Given this list of marker genes ZSWIM1, CSRNP3, TUB, TRERF1, IFT57, PTMS, INO80B (NCBI Gene Id 83444), CCDC13, DCTN3, NUDC, ARFIP1, OSBPL2, LRP10, OSR2, GTF3C1, TEX2, DIS3, MORN4, MBNL2, OSM, C2orf15, P2RY10, NR4A3, DNAAF6 (NCBI Gene Id 139212), NUP62CL, SLCO3A1, HNRNPF, PURG, FRA10AC1, WRN, PIM2, CAMK1, STRN4, RGS6, EFHB, SMARCAD1, FKRP, NR4A1, PIH1D2, CEP135, KCNK12, GLRX5, MID2, PPP1R16A, IL34, RREB1, NOS1, FNDC9, ITGB3BP, DNAJC21, GAST, TBC1D16 (NCBI Gene Id 54493), SREK1, HPCAL1, MAPRE3, FBXL2, PCF11, PIBF1, TSGA10, OTX1, CYRIA, PRRT2, RFX1, CAMK2A, NKAPD1, KIFAP3, WDR47, STAT6, CCDC24, SYT17, DNAJA1, FGF9, SLC9A7, KDM3A, TIGD4, TMEM209, RARA, SLC8A3 (NCBI Gene Id 90450), LINC01567, TMEM254, TSHZ2, MINK1, CHD4, RAB28, UNG, RAB36, GOLM2, MGAT4B, NIM1K, NLGN2, here is a description of the gene set: Human Gene Set: GTTNYYNNGGTNA_UNKNOWN Genes having at least one occurrence of the highly conserved motif M89 GTTNYYNNGGTNA in the regions spanning 4 kb centered on their transcription starting sites. The motif does not match any known transcription factor binding site. Comprehensive identification of all functional elements encoded in the human genome is a fundamental need in biomedical research. Here, we present a comparative analysis of the human, mouse, rat and dog genomes to create a systematic catalogue of common regulatory motifs in promoters and 3' untranslated regions (3' UTRs). The promoter analysis yields 174 candidate motifs, including most previously known transcription-factor binding sites and 105 new motifs. The 3'-UTR analysis yields 106 motifs likely to be involved in post-transcriptional regulation. Nearly one-half are associated with microRNAs (miRNAs), leading to the discovery of many new miRNA genes and their likely target genes. Our results suggest that previous estimates of the number of human miRNA genes were low, and that miRNAs regulate at least 20% of human genes. The overall results provide a systematic view of gene regulation in the human, which will be refined as additional mammalian genomes become available. species: Homo sapiens from publication Xie X, Lu J, Kulbokas EJ, Golub TR, Mootha V, Lindblad-Toh K, Lander ES, Kellis M (PMID 15735639)